Given this list of marker genes E2F7, AKT1, PKD1, ZNF568, CEBPB, SPINT1, ARNT, HAND1, GCM1, MDFI (MyoD family inhibitor), SNAI1, HS6ST1, OVOL2, PLG, HIF1A, FGFR2, JUNB, PLCD3, GRB2, TRIM28, TMED2, PLK4, LLGL2, PRDM1, EOMES, MED1, MAPK1 (NCBI Gene Id 5594), SP3, LEF1, CDX2, GJB5, VASH1, GRHL2, IL10, PDGFB, MAP2K1, VASH2, CDX4, FZD5, IGF2, BIRC6, ZFP36L1, ST14, CITED2, CCN1, WNT2, EGLN1, TFEB, KRT8, RSPO3, PCDHA10, RBPJ, STK4, ASCL2, NCOA1, LIF, TTPA, ADM, BMP5, PCDH12, SOX15, EPAS1, SENP2, CDKN1C, ESRRB (NCBI Gene Id 246148), BPTF, E2F8, HEY1, CITED1, GATA2, FBXW8, HES1, PKD2, NSDHL, PHLDA2, HSF1, TAF10, KRT19, SPINT2, HEY2, SOCS3, GGNBP2, CASP8, NODAL, DNAJB6, STK3, WNT7B, NR2F2, BMP7, ELF5, CEBPA, CSF2, EGFR, here is a description of the gene set: Human Gene Set: GOBP_EMBRYONIC_PLACENTA_DEVELOPMENT species: Homo sapiens The embryonically driven process whose specific outcome is the progression of the placenta over time, from its formation to the mature structure. The placenta is an organ of metabolic interchange between fetus and mother, partly of embryonic origin and partly of maternal origin.